The following is a description of a gene set: Any process that activates or increases the frequency, rate or extent of the formation and development of a tooth or teeth. species: Mus musculus Mouse Gene Set: GOBP_POSITIVE_REGULATION_OF_ODONTOGENESIS, and this is the list of marker genes: Msx1, Tgfb1, Ednra, Mir875, Prkcb, Edn1 (NCBI Gene Id 13614), Csf1, Bmp2, Ngfr, Cd34